The following is a description of a gene set: An abnormally reduced head circumference in a growing child. Head circumference is measured with a nonelastic tape and comprises the distance from above the eyebrows and ears and around the back of the head. The measured HC is then plotted on an appropriate growth chart. Microcephaly is defined as a head circumference (HC) that is great than two standard deviations below the mean of age- and gender-matched population based samples. Severe microcephaly is defined with an HC that is three standard deviations below the mean. Human Gene Set: HP_DECREASED_HEAD_CIRCUMFERENCE Decreased head circumference studied in species Homo sapiens, and this is the list of marker genes: RAB11B, HNRNPH2, GFM1, ADARB1, SNAI2, PEX14, MPC1 (mitochondrial pyruvate carrier 1), AFG2B, PDGFB, GNB5, SATB2, CTNNA2, AGT, NARS1, POGZ, SLC35C1, HMGB3, PPP3CA, GNAO1, BCR, ERCC8, LAS1L, LARP7, POLA1, USP18, DDX6 (NCBI Gene Id 1656), POLR3GL, AP4E1, FGF12, RPL18, SMPD4, PHF6, FKBP6, OSGEP, TRAPPC10, PPP1R15B, BRCA2, NKX3-2, RPS19, TMEM70, ASCC3, STAG1, MTSS2, CAPN15, PHF8, CAMK2B, EN1, CEP63, CDC42, NDUFS4, LFNG, MCTP2, PCNA (proliferating cell nuclear antigen), ZSWIM7, FOXH1, SP110, GTF2H5, DYNC1H1, SLC35A1, ZNF526, SLC1A4, NFIX, BMP4 (bone morphogenetic protein 4), KIF5A, CHRNG, ATP1A3, G6PC3, MED17, SLC35A3, CEP290 (NCBI Gene Id 9707), RFX7, PYCR1, IPO8, CLPP, CLTC, VPS50, ATPAF2, CNOT1, COG1, ATP6V1A, AP4S1 (adaptor related protein complex 4 subunit sigma 1), SNF8, UFC1, SLC32A1, PNPO, GSC, PEX6, MOCS2, ATP1A2, WDR45B, RAD51, SF3B4, ITGB6, CCDC8, CDT1, AUH, TAF4, CARS2 (cysteinyl-tRNA synthetase 2, mitochondrial), SLC13A5, NSRP1, CLCN4, CEP85L, TUBB3, FBXL3, DALRD3, LAGE3, AGGF1, H3-3A, SYNJ1, SLC2A1, ZSWIM6, NDUFAF3, CEP152, QARS1, ELN (elastin), SCN2A, LARS1, VPS11, ESAM, HCCS, PDE2A, SLC6A1, ATP5F1A, SAMHD1, DHCR24, TSEN2, TIMMDC1, PSAT1, MECP2, C2CD3, CENPT, SEC24C, SPTAN1, VPS13B (NCBI Gene Id 54990), TSR2, CLCN3, POR, ATM, NUP188, ALG9, NEUROD2, RIPPLY2, DDX3X, RPGRIP1L, TANC2, ARID2, EFTUD2, PIGP, HEATR3, PAX3, CHRNA7, GALK1, VPS53, ZC4H2, ARCN1, DLD, MRPS25, DOCK6, HMGCL, P4HTM, KATNB1, FBXO28, MCPH1, MINPP1, TRIP12, RPL35A, ZNF292, COL18A1, TRAPPC14, BUD23, COG2, NTNG2, SPOP, MYSM1, TSPEAR, MRPS34, COX15, KCNT1 (NCBI Gene Id 57582), B9D1, DGCR2, NDUFAF1, TSEN54, PUS7, PEX11B, EXOC2, BNC1, NDUFS3, POLR1B, CLIP2, COL4A1, BRD4, CRKL, CPLX1 (complexin 1), TECPR2, TUBB, EXOSC9, PSMB1, MYH3, SLC25A12, RBM28, ZNF699, SERAC1, ARVCF, RAB3GAP2, FANCB, TFAP2A, BRAT1, FANCF, EFEMP2, YWHAG, FRA10AC1, ATR, EBF3, EXTL3, HSPG2, TBCD, SDHAF1, KCNQ2, ZBTB18, NAPB, FH, FANCE, ARSL, VARS2 (NCBI Gene Id 57176), PNPLA6, WDR26, TSEN15, CUL4B, ADA2, XPC, CACNA1B, KAT6B, FBXL4, HSPD1, MBTPS2, ZNHIT3, AP3B2, LARGE1, FILIP1, MARS1, PGAP1, UBE4B, GTF2E2, TUSC3, MT-ND1, PPT1, SLC20A2, SUFU, PIGY, IQSEC1, AIMP1, PRKD1, ITGA3, DCHS1, NACC1, FZR1, PTF1A, OSTM1, MED27, FBXW7, DEAF1, DLL3 (delta like canonical Notch ligand 3), TMEM270, CRIPT, SMG9, PRKAR1B, LDHD, SCAF4, NDUFS1, FAM20C, BICRA, GOT2, DSTYK, OGT, KMT2D, GATA6, IFT140, PIK3R1, HPDL, THOC2, SLC1A2, RSPRY1, RNF13, NCAPD3, CRPPA, ZIC1 (Zic family member 1), WBP11, POLRMT, GLYCTK, AP4M1, SAMD9L, FBXO11, KIF11, MOCS1, INTS11, TBCK, NUP54 (NCBI Gene Id 53371), SUOX, KNL1, LIAS, SNAP29, CIT, HCN1, SALL1, TBX6, DHDDS, IKBKG, PORCN, SARS1, PIGS, RIC1, TRMT10A, CCDC47, CDK10, MYT1L, STAG2 (STAG2 cohesin complex component), CTCF, COG3, NF1, SPART, RPS6KA3, ELAC2, PLEKHG2, ROGDI, EIF2AK2, KDM5C, KCNN2, NADK2, FSHR, YARS1 (tyrosyl-tRNA synthetase 1), GRIN2A, SDHD, CNTNAP1, NANS (N-acetylneuraminate synthase), CTNND2, VARS1, DOLK, NFASC (neurofascin), SEMA3E, DENND5A, PLK4, ASXL1, TDP2, HACE1, SLC9A6, TRIP13, PISD (NCBI Gene Id 29838), SYNE1 (NCBI Gene Id 85448), SNRPN, MAFB, SBF1, MT-ATP8, POC1A, GJA8, NALCN, EIF2B1, GEMIN4, MAPRE2 (microtubule associated protein RP/EB family member 2), ACSF3, HIKESHI, DNAJC21, CTU2, BCAS3, NDUFA2, RPS24, MYMK, LINS1, HES7, LTC4S, GAS1, NDUFA1, NUP37, DSG1, BPTF, SIX6, ALDH6A1, IFT74 (NCBI Gene Id 80173), RTTN, TRAF7, NIPA1, VPS37A, KCNJ6 (NCBI Gene Id 8206), NBN, KMT2B, PTDSS1, HHAT, TMEM165, ADSL (adenylosuccinate lyase), RNASEH2C, CEP135, SMO, ARPC4, DNAJC30, TYMS, VPS33B, RPL9, NARS2, FOXL2, ERCC1, PCLO, VPS13D, SLC25A22, PHC1, COASY, SUCLA2, CNKSR2, QDPR, RHOBTB2, OFD1, LSS, COG7, ITPA, EXOC7, ZIC2, TBC1D24, DMXL2, PHACTR1, IGF1, CHKB, CTBP1, SPR, TMTC3, YIPF5, HNRNPU, SIL1, PPFIBP1, ARX, ZBTB11 (NCBI Gene Id 27107), TUBG1 (NCBI Gene Id 7283), MAB21L1, TOR1A, MYCN, SMAD4, NCAPD2, RPL31, NSMCE2, L1CAM, RPL27, CENPJ, ZNF668, CDK6, WLS, ELOVL4, COMT, EP300, ASPM, SRPX2, PIGH, TMEM231, PRDX1, ADGRG1, BUB1, MESP2, ERCC6, TP53RK, MAP1B, MICU1, SMARCA2, TPRKB, MTR, ATRIP, NR5A1, FRAS1, RPL8, GJB4, PEX3, SLC38A3 (NCBI Gene Id 10991), PTS, AP1S2, TNPO2, FDXR, NDUFA8, OCLN, PPP2CA, CC2D1A, DPYD, C2orf69, RFC2 (NCBI Gene Id 5982), FKTN (NCBI Gene Id 2218), PEX26, B3GALNT2, ATP6V1B2, TUBGCP6, EFNB1, PPP2R1A, RBBP8, RAP1GDS1, THOC6, TREX1, RAD50, DRG1, KDM6A, ARNT2, B4GAT1, VPS37D, RPS15A, RPS26, NSUN3, AMFR, METTL5, IER3IP1, SUCLG1, RAC1, ALG2, RFWD3, ALS2, HDAC4, ARID1A, IGF1R, OTUD5, DNA2, UBE3A, IQSEC2, GATA4, ALX4, MTFMT, PDHA1, SMG8, LGI3, TBX1, SMC3, UBR1, SRRM2, ERCC4, POLH, SDHB, NTNG1, TMEM222, SCO2, NDUFA11, POLG, CYP26C1, FARSB, STX1A, PSAP, STXBP1, GRIN2D, NSUN6, POLD1, TEFM, XRCC2, FRMD4A, SLC35A2, ADD3, PIK3CA, NSUN2, KCNC2, MICOS13, RAB18, SC5D, SLC25A46, DAG1, SIN3A, EPRS1, CENATAC, XRCC4, UFD1, SCN1B, BRIP1, CHD2, HPD (NCBI Gene Id 3242), RTEL1, UBE2T, QRICH1, FZD4, ACBD5, TBC1D20, SCUBE3, LINGO1, PEX10, LETM1, ROBO3, MAD2L2, PLAG1, ACTG2, GTPBP2, TMEM237, TBC1D23, POLR3H, HSD17B10, STAC3, SPG11, ZNF335, MBD5, ALDH3A2, TMX2, FKRP, MRPS28, SNUPN, KARS1, OTUD6B, PEX19, NHP2, NDE1, SLC25A24, SLC6A9, NHEJ1, SHMT2, RAD21, CDCA7, ANKRD17 (NCBI Gene Id 84177), DPF2, CASK, STIL, CPT2, DNMT3A, ATP6V1E1, YIF1B, TRAPPC2L, NODAL, RNU12, RNU4ATAC, SMC5, COX7B, GTF2IRD1, COG4, DPH2 (NCBI Gene Id 1802), FGFRL1, MGAT2, PLAA, ALG3, EIF5A, CDKL5, SEPSECS, PIGF, MYORG, DISP1, RAB3GAP1, CENPF, DONSON, CWF19L1, AMPD2, POMT1, PGAP2, EOMES, ADAM22, MRPS22, RBMX (RNA binding motif protein X-linked), PIGW, AFF4, CYB5R3, SLC5A6, DEGS1, SPTLC1, ATP7A (ATPase copper transporting alpha), RAP1B, TRAIP, WDR62 (WD repeat domain 62), SLC25A1, SCN1A, NUP133, PAH, WARS1, CREBBP, ADAMTSL1, DPYS (dihydropyrimidinase), SPEN, CACNA1G, MACF1, POLR2A, TAF13, DNAAF4, GORAB, SCYL2, GNPAT, MRAP (melanocortin 2 receptor accessory protein), TET3, FREM1, BRF1, PIGQ, SHANK3, USP7, LONP1, ATP6V0A2, TOP3A, SMARCE1, NEK9, PEX2, HNRNPC, H4C3, ASPA, NGLY1, NELFA, GABRA5, NSF, TRPS1, GP1BB, DHCR7, FTH1, EIF4A2, MYO18B, GFM2, RPS10, RPS29, TOMM7, TBL2 (NCBI Gene Id 27203), DHX37 (DEAH-box helicase 37), KCTD7, CNTNAP2, MSH4, CKAP2L, TUBB2B, DCC, BCOR, FBN1, TBCE (tubulin folding cofactor E), THUMPD1, LRP5, ACADSB, TRAPPC11, NDUFS7, KDM5A, MEG3, MPDZ, KCNA1, SLC39A14, ST3GAL5, BCL11A, GNPTAB, UBTF, MAPK8IP3, MAPK1, EMG1, KIFBP, TCTN1, PLP1, GABRA2, CAMK2A, FBLN5, WWOX, CRIPTO, TRAPPC4, CRELD1, GRIN1, PYCR2, EXT1 (exostosin glycosyltransferase 1), NSD2, TRAPPC6B, ACE, SMARCD1, CELF2, NDUFAF4, ANK1, PACS2, ATP9A (ATPase phospholipid transporting 9A (putative)), SUPT16H, JAM2 (NCBI Gene Id 58494), DCX, RTL1, DDB2, NDUFS6, BAZ1B, EFL1, H3-3B (NCBI Gene Id 3021), MTHFR, ABCA2, GMNN, KIF1C, AFG2A, SZT2, KAT6A, COG6, AP4B1, TERT, MMACHC, FANCC, DNM1L (NCBI Gene Id 692222), KCNAB2, POMK, PPP1R12A, FANCG, ANK3, POLR1A, RPL5, GLI2, RNASET2, ACADVL, PIDD1, PEX7, SV2A, HNRNPH1, ATRX, ADAT3, TUBGCP4, UFM1, HUWE1, RFT1, ORC6, RREB1, TAF6, LMNB2, NIPBL, RIPK4, RPL10, DGUOK, GON7, MFSD2A, TP53, BUB1B, HNRNPK, NDUFAF2, ALG12, DOHH, CASZ1, SLC4A10, ADPRS, RB1, RARS2, NDUFV2, PIGG, LMBRD2, COPB1, TAF1, DPM2, NAT8L, PI4KA, CHD6, COG5, AP2M1, LEMD2, ACTL6B, GRIA2, ACADS, GTF2IRD2, FTO, NDP, KCNJ2, CDK19, SIK1, MSMO1, GALC, DCPS, NUS1, ERCC6L2, VPS4A, HDAC8, PHGDH, CYB5A, CYFIP2, SDHA, PTRH2, RUSC2, GRIP1, EIF4H, ADAR, MCM7, VAC14, YME1L1, DKC1, NDUFAF5, EXOC8, MAD1L1, FGFR3, MORC2, LRPPRC, SNAPC4, ACTB, GNB1, H4C5, NAA10, PUS1 (NCBI Gene Id 80324), RPL11, CDK5RAP2, TMEM260, CHD8, CERT1, PSMC3IP, POMGNT1, DYM, SCN3A, ZMYM3, PIK3CD, NEXMIF, TRIT1, FGD1, RERE, HNMT, MED23, PIGA, ALG1, ACSL4, COQ9, DLK1, KIF5C, SLC6A8, DLL1, SLC12A5, TMEM163, BCKDK, TLK2, CEP295, TRAK1, SET, PET100, MAPKAPK5, TBX4, SLX4, GABRB2, PI4K2A, RBPJ, WBP4, ANKLE2, CACNA1A, EXOSC5, RELN, SLC25A20, NUBPL, RAD51C, PUS3, CDON, VRK1, ZEB2, SNRPB, PCDHGC4, NTRK2, SOX2, KCNMA1, CTNNB1, NUP214, EEF1A2, SMARCA4, AUTS2, PURA, ASNS, PEX16, LEMD3, DTYMK, CFC1, KCNA2 (potassium voltage-gated channel subfamily A member 2), DHTKD1, KCNH1, PRKCZ, RPS20, PRUNE1, FANCI (FA complementation group I), MVK, XPA, CCDC88A, TSEN34, ASXL3, MEIS2 (Meis homeobox 2), COX8A, NDUFS2, PRORP, TNRC6B, TAT, STT3B, SETD2, PALB2, CPSF3, MPLKIP, CCDC32, ERCC3, KDSR, NOP10, PIGV, SYNGAP1, LUZP1, EXOSC1, SVBP, FARS2 (NCBI Gene Id 10667), RNF168, KIF14, CLPB, ADH5, RPL26, NDUFS8, MED25, RAI1, SIGMAR1, PEX12, NAA60, PRKDC, CD96, WDR11, ATP5PO, GABBR2, MPV17, RPS28, GBA1, YRDC, RXYLT1, REN, SHH, MCOLN1, ZMYM2, GRM7, TGIF1, EXOSC8, TRIO, AHDC1, GCSH, COX11, RPS17, EXOSC3, TRRAP, PDCD6IP, PLCB1, MCM4, WDR4, TTI1, XPR1, PMPCB, B3GLCT, UBA5, SLC30A10, SOX11, ORC4, CTSD, UQCRC2, HCFC1, RPS27, TUBGCP2, KANSL1, BRCA1, NDUFB11, DHX9, AAAS, YARS2, MESD, MIPEP, HIRA, BUB3, EHMT1, PIGL (NCBI Gene Id 9487), PCNT, PDPN, TTC5, NUP107, KIF15, SKI, ATP10A, ALDH18A1, LMX1B, TCTN2, CDC6, BDNF, MT-ND3, SUMF1, B9D2, NCAPG2, INSR, MPDU1, DDX59, CHKA, JMJD1C, NDUFA6, CDK13, TUBB4A, SIN3B, PDGFRB, TRIM8, BCAP31, GPKOW, ATP11A, PARN, LIPT2, RNASEH2A, SRCAP, ARHGAP31, SELENOI, EPG5, CHAMP1, TANGO2, MKS1, GPT2, HTRA2, COPB2, PIEZO2, IFIH1, RNU4-2, INPP5E, MYMX, RNASEH2B, JAM3, PAK3, FAT4, NKX2-1, PAFAH1B1, PRIM1, EIF2AK3, CSNK2A1, TUFM, SIX3, RNPC3, RNF2, ITPR1, TPK1, HAAO, UPB1, TRAPPC12, MED12, ATP5MK, PCDH12, GRIA4, NECAP1, FLCN, CHD7 (NCBI Gene Id 780907), TTI2, PAX6, GLS, FUT8, GET4, JARID2, WDR73, AARS1, FANCL, CENPE, GTF2I, CNNM2, PAPPA2, FGFR1, TRAPPC9, MMP23B, LIG4, RLIM (NCBI Gene Id 51132), FLII (FLII actin remodeling protein), RPL35, TSPAN12, TRMT1, TASP1, TMEM126B, MANF, SMARCC2, ALG13, TXN2, NAGS, GMPPA, DLAT, GINS1, LSM11, TAPT1, METTL27, ARHGEF2, ERCC2, CLP1, TARS1, STAT5B, MDH1, FOXRED1, NSDHL (NAD(P) dependent steroid dehydrogenase-like), KIT, AP3B1, AGA, NDUFB3, CDC45, HMGA2, SMARCB1 (NCBI Gene Id 6598), TMCO1, STAMBP, NUP85, AIMP2, CNP, FAR1, AP3D1, CBL, UFSP2, ADNP, SASS6, PCGF2, KCNB1, STT3A, GATA1, ACO2, GJA1, FUS (FUS RNA binding protein), RNF113A, TAF2, GABRG2, SLC30A9, ACTG1, HBA2, NSD1, RSRC1, KYNU, AFF2, DHFR, CEP57, SPIDR, POLR3B, BRPF1, FREM2, DPAGT1, ESCO2, MTRR, MGME1, SLC12A6, PUF60, IARS1, DDX11, MTHFS, ORC1, TELO2, PRDM16, CHN1, ZNF408, MID1, EIF3F, OCA2, MT-ATP6, PMM2, RPS23, UGDH, PLPBP, FARSA, CDC42BPB, GRIN2B, ISCA1, NCAPH, TINF2, SEMA5A, FLVCR2, TMEM107, ESS2, NDUFC2, PARS2, WT1, AFF3, MFF, NDUFB9, CDH11, PEX1, PQBP1, EXT2, FANCA, DNM1, ZPR1, SLC25A19, MBOAT7, CARS1, DPM1, GABRD, PEX5, SLC18A2, AHCY, SPTBN1, FIG4, ENTPD1, ACD (ACD shelterin complex subunit and telomerase recruitment factor), NDUFAF8, U2AF2, RPGRIP1, DHX30, NBEA, PTEN, UBE3B, PNPLA2, VPS51, PRMT7, INPP5K, PEX13, RPL15, GLE1, TMEM67, PACS1, SALL4, AASS, DGCR6, TOE1, PUM1, VIPAS39, ERCC5, RPS7 (NCBI Gene Id 6201), SATB1, CUL3, HNRNPR, TUBA1A (NCBI Gene Id 95407), POMT2, RNU7-1, NCF1, KIF1A, CDK5, SLC16A2, ATP5F1E, COG8, XYLT1, NIN, PDHX, PIGO (phosphatidylinositol glycan anchor biosynthesis class O), NDUFB10, SCN8A, UNC80, BLM (BLM RecQ like helicase), CSPP1, DYRK1A, MT-ND2, VPS33A, EIF2S3, LMNB1, PNKP, LAMB2, PTCH1, ATP5F1D, GOLGA2, KMT2C, RARS1, AGTPBP1, DPP6, SGPL1, ARID1B, PTPN23, UGP2, AGTR1, TCTN3, IBA57, PLXNA1, ALG11, MASP1, POLR3K, HBA1, POMGNT2, CHMP1A, TMEM216, PSPH, FOXG1, KMT2A, EDC3, WDFY3, FGF8, KAT5, SSR4, TBL1XR1, INTS8, PLCH1, ZNF592, KCNA4, BMP15, PSMC1, ZNF148, CC2D2A, KIF2A, NRCAM, GMPPB, POLE, AHSG, GRIK2, ARFGEF2, ANKRD11, DYNC1I2, NDUFV1, FANCD2, NIPA2, PRR12, MIR17HG, TCF4, GJB3, LIMK1, HIVEP2, SMC1A, GALNT2, CRLS1 (NCBI Gene Id 54675), EMC1, FANCM, TXNDC15, PGAP3, CACNA2D1, WDR37, DGCR8, WASHC4, ASH1L, SOX4, RECQL, GJA5, RRP7A, DIAPH1